The following is a description of a gene set: studied in species Homo sapiens Lymphangiectasis Human Gene Set: HP_LYMPHANGIECTASIS Dilation of the lymphatic vessels, the basic process that may result in the formation of a lymphangioma., and this is the list of marker genes: MPI, HRAS, SOX18, FAT4, ADAMTS3, RNF31, CCBE1, FOXF1, CD55, PIEZO1